The following is a description of a gene set: Mouse Gene Set: WP_MICROGLIA_PATHOGEN_PHAGOCYTOSIS_PATHWAY Microglia pathogen phagocytosis pathway studied in species Mus musculus, and this is the list of marker genes: Pik3c2a, Vav2, Fcgr1, Vav3, Pik3cb, C1qb, Lyn, Trem3, Ncf1, Cyba, Pik3r6, Pik3r2, Pik3c3, Ncf2, Pik3r3, Ptpn6, Ncf4, Vav1, Pik3cd, Rac1, Syk, Itgam, C1qa, Pik3r1, Fcer1g, C1qc, Pik3cg, Rac3, Trem1, Hck, Cybb, Siglece, Lat, Plcg2, Pik3ca, Itgb2, Rac2, Nckap1l, Tyrobp, Trem2, Arpc1b